Given this list of marker genes AGO3, TARBP2, AGO2, LIN28A, TUT4, BCDIN3D, TRUB1, AGO4, DROSHA, PRKRA, DICER1 (dicer 1, ribonuclease III), TUT7, DGCR8, AGO1, ADAR, HOXB-AS3, LIN28B, here is a description of the gene set: species: Homo sapiens Human Gene Set: GOBP_PRE_MIRNA_PROCESSING A process involved in the conversion of a pre-microRNA transcript into a mature microRNA molecule.